Given this list of marker genes Elavl2, Ing3, Rhox2a, Slco1b2, Fam133b, Socs6, Hapln1 (NCBI Gene Id 12950), P2ry1, Zfp960, Fabp12, Trim36 (NCBI Gene Id 28105), Zfp84, Spock3, Gm5591, Wnk3, Rlig1, Setdb1, Fam174a, Ago4 (NCBI Gene Id 76850), Glb1l3, Tmem65, Nlk, Eif4enif1, Rab21, Hacd2 (3-hydroxyacyl-CoA dehydratase 2), Sp3, Cp, Prr7, Tcf7l2, Cep57l1, Cacnb4, Ube2v2, Synj2bp (synaptojanin 2 binding protein), Spinkl, Ufl1, Lhfpl3, Snapin, Fam98a, Slc35f3, Ppp2r1b, Zbtb11, Dnajc18, Kcnk10, Cdk6, Retreg1, Pira12, Nwd2, Phip, Jmjd1c, Pgap1, Pcm1 (pericentriolar material 1), Slitrk4, Parp14, Tceal9, Hspa4l, Lrrtm2 (NCBI Gene Id 107065), Fbxo33, Lhx6, Ube3a, Usp34, Rab11fip2, Slc24a2, Rbm26, Elavl4, Slc15a2 (NCBI Gene Id 98014), Smurf2, Ptpn9, Krcc1, Bcap29, Zfp97, Itch, Id4, Kdm2b, Slc30a1, Rab3c, Dact3, Tmem237, Abca5, Rai1, Slc10a7, N4bp2l2, Pde6d, Cd109, Smurf1 (SMAD specific E3 ubiquitin protein ligase 1), Atp2b1, Dusp10, Etnk1, Znrf3, Sephs1, Dcun1d5, Kcmf1, Csnk2a2, Unc5d, Tshz1, Dach2, Abca1, Asb5, Slc4a10, Hook3, Papolg, Nxpe3, Rnf4, Tent4b, Plch1, Pard6b, Pdzk1, Utrn, Tcaim, Cep170, Deptor, Rps6kb1, Bnc2, Cttnbp2, Clcn3, Mgat4a, Tmem169, Trim21, Zfp398, Cntn4, Thsd4, Lmbr1, Lmbrd1, Rnf19a, Tmem204, Gucy1a2, Arhgap29, Sec23ip, Zfp280c, Tmem184c, Cnot6, Snx16, Plxdc2, Vma21, Ogfrl1, Nrxn1, here is a description of the gene set: from publication Chen Y, Wang X (PMID 31504780) Genes predicted to be targets of miRBase v22 microRNA mmu_miR_379_3p, mmu_miR_411_3p in miRDB v6.0 with MirTarget v4 prediction scores > 80 (high confidence targets). studied in species Mus musculus Mouse Gene Set: MIR_379_3P_MIR_411_3P